Given this list of marker genes Gm41225, Gm4355, Diaph3, Tdrd3, Gm49060 (NCBI Gene Id 115488295), Gm33121, Gm33203, Gm9264, Gm32729, Gm32815, Gm9275, Pcdh20, Gm4350, 4930529K09Rik, Gm25115, Gm23926, Gm48929, Gm32913, Rps3a2, Gm9274, Gm18812, Gm23278, here is a description of the gene set: studied in species Mus musculus Mouse Gene Set: chr14E1